The following is a description of a gene set: Epigenetic regulation of gene expression species: Mus musculus Mouse Gene Set: REACTOME_EPIGENETIC_REGULATION_OF_GENE_EXPRESSION, and this is the list of marker genes: Wdr82, Taf1a, Zfp354a, H2bc21, H4c8, Mybbp1a, H4c4, H3c3, H2ab1, Rbbp4, Kmt2d, Gm5141, H4c1, H2ac4 (NCBI Gene Id 319172), H4c17, Ep300, H3f3a, H3f3b, Jarid2 (NCBI Gene Id 97879), H3c2, Ercc6, Zfp1004, Wdr5, Zfp975, H2bc14, Zfp937 (NCBI Gene Id 245174), Polr2h, Polr1b, Cxxc1, Hcfc2, Tdg, H2az2, Rbbp7, Zfp433, Myo1c, Kansl3, H2ac15, H2ac18, Rbbp5, Polr2e, Psip1, Mcrs1, Dnmt3a, Zfp872, Zzz3, Zfp950, H2ac7, Sf3b1, H2ab2, Gm6871, Pagr1a, Zfp54, B020011L13Rik, H2bc26, H2bc24, H2bc13, H4c2, H2bc11, Abl1, H3c10, Ezh2, Rxra, H2ac22, Zfp454, Mbip, Polr1c, Taf1b, Suz12, Zfp324, Gm10778, Polr1f, H2ax, Zfp97, Zfp997, H4c14, H2bc12, H2bc4, Ncor2, Setd1b, Gm4767, H2bc7, Zfp934, H2ac23, Gm3604, Mtf2, Hdac3, H2ac8, Tbp, Kansl2, Atf7ip, H3c13, Tada3, Zfp1007, Tbl1xr1, H2bc15, Taf1c, Gsk3b, Kat14, H2ab3, Yeats2, Polr2f, H2ac6, H4c18, Baz1b, Men1, H3c4, Zfp442, H4c16, H2bc8, Hcfc1, H2ac24, H2bc23, Tada2a, H4c9, Ogt, H2ac12, H3c15, H2bc1 (H2B clustered histone 1, NCBI Gene Id 319177), Zfp382, Dnmt1, H2ac11, H2ac19, Ash2l, Smarca5, H2bc22, Kat2a, Kmt2b, H3c6, Eed, Polr1a, Zfp960, H3c8, Zfp873, Polr1e, Gps2, Ddx21, Polr1h, Akap8l, Zfp160, Setd1a, H2bc6, Phf20l1, Zfp53, H3c7, Zfp708 (zinc finger protein 708), Kmt2a, BC024063, Taf1d, Phf19, H3c1 (NCBI Gene Id 360198), Gm14399, Aebp2, Phf20, H2ac13, Tbl1x, Phf1, Zfp317, Kansl1, H2bc9, H4c12, Actb, Dek, Zfp345, Zfp976, H4c6, Zfp970 (NCBI Gene Id 628308), Zfp677, Kat2b, Dr1, Bod1l, 4930522L14Rik, Setdb1, Paxip1, H2aj, Polr1g, Zfp932, Dnmt3b, H2bc3, H3c14, H2ac20, Tasp1, H4c11 (NCBI Gene Id 319159), Kat8, H2ac10, H4c3, Polr2l, Trim28, Polr2k, Sgf29, H3c11, Kdm6a, Gm15446